Given this list of marker genes GNAQ, PLCB3, GNA11, PLCB2, PLCB1, PLCB4, here is a description of the gene set: Pathway Definition from KEGG: UL33 -> (GNAQ,GNA11) -> PLCB Human Gene Set: KEGG_MEDICUS_PATHOGEN_HCMV_UL33_TO_GNAQ_PLCB_G_CALCINEURIN_SIGNALING_PATHWAY species: Homo sapiens HCMV UL33 to GNAQ-PLCB/G-calcineurin signaling pathway. Pathway ID: N00407. Pathway type: Pathogen. Pathway class: nt06167 Human cytomegalovirus (HCMV).